Given this list of marker genes Tecta, Myo7a, Trip11, Sdc4, Tprn, Grxcr1, Vangl2, Pdzd7, Slc4a7 (solute carrier family 4, sodium bicarbonate cotransporter, member 7), Ripor2, Rest, Wdpcp, Tmc1, Ift27, Pls1, Atp8b1, Hes1, Nherf1, Ift20, Ush1c, Whrn, Fzd2, Sec24b, Elmod3, Myo3b, Rac1, Cthrc1, Gabra5, Otog, Gabrb3, Pcdh15, Clrn1, Ptprq, Ush1g, Adgrv1, Tshr, Hey1, Ankrd24, Tomt, Naglu, Strc, Grxcr2, Pafah1b1, Cecr2, Triobp, Ift88, Sod1, Clrn2, Alms1 (ALMS1, centrosome and basal body associated), Slitrk6, Cdh23, Clic5, Tsku, Minar2, Fat4, Myo3a, Atp2b2, Otogl, Scrib, Lhfpl5, Fgfr1, Dicer1, Mks1, Hes5, Gabrb2, Pjvk, Kif3a, Alg10b, Ttc8, Mir96, Kcnq1, here is a description of the gene set: studied in species Mus musculus The process whose specific outcome is the progression of an inner ear receptor cell over time, from its formation to the mature structure. Cell development does not include the steps involved in committing a cell to a specific fate. Mouse Gene Set: GOBP_INNER_EAR_RECEPTOR_CELL_DEVELOPMENT